Given this list of marker genes Slc22a1, Slc6a3, Actb, Slc6a2, Slc29a4, Slc22a2, Slc22a3, Snca, Slc18a1, here is a description of the gene set: The directed movement of norepinephrine into a cell, typically presynaptic neurons or glial cells. Norepinephrine (3,4-dihydroxyphenyl-2-aminoethanol) is a hormone secreted by the adrenal medulla and a neurotransmitter in the sympathetic peripheral nervous system and in some tracts of the CNS. It is also the biosynthetic precursor of epinephrine. Mouse Gene Set: GOBP_NOREPINEPHRINE_UPTAKE species: Mus musculus